The following is a description of a gene set: Follicular hyperplasia Human Gene Set: HP_FOLLICULAR_HYPERPLASIA studied in species Homo sapiens Lymphadenopathy (enlargement of lymph nodes) owing to hyperplasia of follicular (germinal) centers., and this is the list of marker genes: TNFRSF13B, SYK, FAS, ICOS, CD19, CTNNBL1, CASP10, STING1, FASLG, CR2, PRKCD, KRAS, NRAS, TNFRSF13C, TET2